The following is a description of a gene set: Human Gene Set: GOCC_OLIGOSACCHARYLTRANSFERASE_COMPLEX_B species: Homo sapiens An oligosaccharyltransferase complex that contains STT3B as the catalytic subunit., and this is the list of marker genes: STT3B, DDOST, TMEM258, OST4, RPN2, MAGT1, DAD1, RPN1